The following is a description of a gene set: from publication Chen Y, Wang X (PMID 31504780) Mouse Gene Set: MIR_7232_5P studied in species Mus musculus Genes predicted to be targets of miRBase v22 microRNA mmu_miR_7232_5p in miRDB v6.0 with MirTarget v4 prediction scores > 80 (high confidence targets)., and this is the list of marker genes: App, Gpkow, Cadps (NCBI Gene Id 27062), Optc (NCBI Gene Id 269120), Ice2, Ywhab, Wdcp, Ppp1r8, Etnk1, Tefm, Epas1, Rapgef2, Myh10, Homer1, Col3a1, Zfp983, Slc26a6, Myt1l, Mier3, Sema4d, Csgalnact2, Angel1, Pik3c2a, Zfand5, Tlk2, Ipp, Ano9, Sacm1l, Cilk1, Btbd35f10, Gtf2ird1, Zc2hc1c, Tmed7, Dsg2, Mpp7, Mnt, Rita1, Btk, 3110082I17Rik, Prkd3, Tmf1, Klf3, Slbp, Cep350, Chd6, Cd46, Btbd35f20, Bahd1, Btbd35f16, Magi2, Btbd35f13, Msrb3, Pnrc1, Uty, Sec62, Leng8, Col15a1, Sox11, Ago4, Uvrag, Btbd35f17, Fdx1, Mroh6, Srgap2, Dnajb14, Fos, Usp21, Fbxo8, Chn2, Dock7, Kcnma1, Pafah1b1, Dynap, Twf1, Ldb2, Cmklr1, Usp53, Plcb1, Gabra2, Pitx1, H2-M10.3, Zdbf2, Phldb2, Abhd13, Btbd35f12, Edc4, Stx3 (syntaxin 3), Btbd35f2, Nwd2, Ttyh3, Tsr2, Txnrd1, Ap1s2, Cdc42ep3, Btbd35f1, Cdh2 (NCBI Gene Id 12558), Slc5a12, Btbd35f15, Wdr26, Tmem235, Btbd35f7, Rnf14, Btbd35f4, Btbd35f28, Btbd35f11, Btbd35f18, Bivm, Rgmb, Igf1, Ccser2, Fhip1b, Dhx57 (NCBI Gene Id 211921), Bex6, Efcab7, Tecpr2, Il1rl1, Elavl2, Btbd35f5, Gga2, Abcf3, Nrxn1, Gtf2e1, Mettl25b, Btbd35f3, Hacd3, Myc, Abca8a, Rassf8, Sox2, St8sia2 (ST8 alpha-N-acetyl-neuraminide alpha-2,8-sialyltransferase 2), Gata6, Hace1, Lamp2 (lysosomal-associated membrane protein 2), Qdpr, Orc4, Slc7a11, Rhot1, Satb2, Zeb1, Dab1, Utp15, Csmd1, Far2, Ywhaz, Arsk, Elfn1, Mark2, Hnrnpab, Tdrd3, Btbd35f21, Ppp4r3b, Rybp, Tacc1, Atp5mc3, Btbd35f27, Mrps25, Fastkd3